Given this list of marker genes CD74, FSHB, AGER, FBN1, RIPK1, HSPA1B, ANKRD54, SMARCC1 (NCBI Gene Id 6599), BRD1, TLR3, RARG, ING5, RIPK2, AP3B1, JAK3, CREB1, FADD, SLC46A2, JUNB, MEF2C, CARD11, BTK, TCTA, HSF1, BRD2, LAG3, SLC4A2, MYB, PTPN2, NF1, POU4F2, H4C14, VNN1, C1QC, GATA2, ERBB2, MIR221, TRAF6, IFNG, STAT1, PF4, SLC9B2, ISG15, PRKDC, SART1, MAPK14, TNFAIP6, TNF, GAS6, CCL3, TNFSF9, TREM2, ANXA1, SOCS1 (NCBI Gene Id 8651), FBXW7, BRPF1, IFNL1, ZNF675, GLI2, MYSM1, TLR4, CTNNB1, LIF, SOCS5, STAT5A, PTPN6, LGALS3, ZFP36L2, HAX1 (HCLS1 associated protein X-1), MTOR, LOX, ADIPOQ, ZBTB7B, SNAI2, ACTB, B2M, DDRGK1, IRF7, JAG1, GPR171, KAT6B, H4C11, FOXN1, IAPP, CD86, ITPKB, ARID1B, H4C9, L3MBTL1, IL5, ACIN1, SKIC8, TESC, NDFIP1, OCSTAMP, GFI1B, TGFB1, KCNK18, PGLYRP1, LTF, IL17A, TNFSF11, DLL1, LILRB2, CCR2, TOB2, CCL19, FOS, PRXL2A, PTPRC, ZFP36L1, TNFRSF11B, EVI2B, GPR68, IL12RB1, NLRP3, PLA2G3, NKAP, H4C5, GABPA, CD101, MALT1, CTNNBIP1, CSF3R, CUL4A, IL15, SIGLEC15, ZBTB16, IL4, LILRB3, SCIN, RUNX3, ACTL6A, ZAP70, SHH, FSTL3, CLDN18, SOS2, KLF13, RHEX, PRELID1, GPR65, CD27, SOD1, RPTOR, SH3RF1 (SH3 domain containing ring finger 1), LGALS9, TYROBP, HLA-G, CTLA4, H4C3, FES, IL4I1, KAT6A, TAOK3 (NCBI Gene Id 51347), BATF, ZFP36, PITHD1, AMBRA1 (autophagy and beclin 1 regulator 1), PRMT6, ARID2 (NCBI Gene Id 57676), ACVR1B, CSF1, SMARCD3, IKZF3 (NCBI Gene Id 22806), IHH, TM4SF19, TRIB1 (NCBI Gene Id 80272), CD69, RAG2, BAD, ADAM8, H4C15, PHF10, BMP4, FCGR2B, RAG1, FOXP1, LEO1, RAB7B, SPI1, BRD7, PIK3R1, RC3H2, FGL2, HOXA9, TAL1, NCKAP1L, PRKCA, HOXA5, TBX21, SMARCC2, IL21 (NCBI Gene Id 59067), FOXO3, H4C16, DCSTAMP, BRPF3, PRDX2 (peroxiredoxin 2), IL18, P4HTM, TMEM131L, GLI3, NOTCH2, IL20, RCOR1, ZC3H8, NFKBID, LDB1, IL23A, TNFSF4, MIR486-1, HIF1A, FCRL3, MMP14, TSC22D1, KAT2A, IL17D, ZFPM1, GPR55, FAXDC2, IFNB1, NFAM1, LYN, SHB, CARTPT, PRDM16, INPP5D, IFNA2, IL7R, CRTAM, KAT7, STAT5B, PURB, LILRB4, EP300, WNT10B, ERFE, CLEC4G, MDK, SOX4, CEACAM1, MEAF6, CDKN2A, MIR21, LOXL3, QKI, OPA1, H4C12 (NCBI Gene Id 8362), IRF4, CTR9, XRCC6 (X-ray repair cross complementing 6), HLA-DRA, INHA, FOXP3, RBM15, SMARCA2, NFKBIA, HSPA9, ZBTB1, TMEM64, SOX13, LCK, MIR222, BCL6, MED1, STAT3, METTL3, APCS, SOS1, HMGB3, IL36B, IL10, MIR125B1, EIF6, PNP, CD46, HOXA7, IL1RL2, ABCB10, ZC3H12A, CASP8, H4C2 (NCBI Gene Id 8366), RHOH, RASGRP1, CAMK4, RARA, MAFB, SENP1, HLA-DRB1, ID2, SYK, ZMIZ1, TCF7, PRDM1, NFKBIZ, CLPTM1, ARID1A, VSIR, SMAD7, SMARCE1, ASCL2, MEIS1, PSG9, PBRM1, ADA, CD28, TOX, ETS1, IL2RA, EGR3, TGFBR2, PIK3R6, TESPA1, CD2 (NCBI Gene Id 914), PAF1 (PAF1 homolog, Paf1/RNA polymerase II complex component), TFE3, SMAP1, FOXJ1, DTX1, PGLYRP2, BRD4, PRMT1, CDC73, GATA3, KLHL25, IL15RA, CD80, IL7, IL23R, HLA-DOA, TMEM178A, PCID2, LEF1, H4C8, GATA1, ACTL6B, FANCA, FANCD2, IL27, CEBPB, MIR223, MEIS2, TLR9, CBFB, MIR145, GPR137, H4C13, CNOT4, ZBTB46, PPP3CA, HMGB1, SPINK5, LILRB1, TMEM176B, TNFSF18, INHBA, RASSF2, FSHR, HCLS1, H4C4, SOX12, ZNF16, MYC, CD83 (NCBI Gene Id 9308), DUSP10 (NCBI Gene Id 11221), SMARCB1, CEBPA, KLF10, ARNT, CDK6, BRAF, MITF, KITLG, CIB1, HMGB2, PTK2B, MPL, CSF3, PCK1, CD4, EEIG1, ACVR2A, BGLAP, IL2RG, ZEB1, UBASH3B, MIR30B, HLX, DROSHA, RUNX1, HLA-B, H4C1, MAPK11, PTN (NCBI Gene Id 5764), PPARGC1B, TNFRSF11A, CYP26B1 (cytochrome P450 family 26 subfamily B member 1), CALCA, LRRC17, LGALS1, PIAS3, ZNF683, SMARCD2, IL4R, SASH3, PPP2R3C, POU4F1, AP3D1, RHOA, IL2 (interleukin 2), MTURN, TCIM, MIR17HG, THPO, SFRP1, H4C6, XBP1, SLAMF8, CCR1, RB1, NRARP, CR1, IRF1, PRKCZ, SMARCA4, BTN2A2, RNF41 (ring finger protein 41), GPR137B, TMEM176A, FAM210B, IL12B, GLUL, SMARCD1, HSPA1A, IL34, CLEC12A, AXL, HOXB8, CYLD, NEDD9, ABL1, PGLYRP3, YPEL4, KAT5, FBXO7, RC3H1, here is a description of the gene set: Human Gene Set: GOBP_REGULATION_OF_HEMOPOIESIS species: Homo sapiens Any process that modulates the frequency, rate or extent of hemopoiesis.